Given this list of marker genes JCHAIN, ANAPC16, AP2A2, MTCH1, CEBPB, SMYD1, FAM3B (FAM3 metabolism regulating signaling molecule B), JPH3, ZC3HC1, CAPN5, CPT2, NDRG3, FGF8, SLC2A2, POLDIP3, SLC29A1, MAPK9, TIMELESS, CDC45, CTTN, CHIC1, UFD1, NPY1R, AXL (NCBI Gene Id 558), F5, RAB3D, AGTRAP, SLC22A9, TBC1D22A, FAM241A, DXO, ARF5, CHMP3, TUBB, RTL6, MYCBP, SYNGR2, SURF4, GTF2H4 (NCBI Gene Id 2968), CENPE, SUV39H2, PRLR, KRT18, S100A14, GNA12, NDC80, PSMD5, EXO1, HSF2, HPS1, SYNGR1, SAA4, PKN2, TNFRSF11A, MCM7, MTMR10, CANT1, NDE1, SDC4, BCL2L1, SMAD3, TRPC4, ARFGAP3, NUP85, PPP6R3, VPS72, OMD, EPB42, RENBP, CD47, NUP107, DNTT (NCBI Gene Id 1791), SEMA3E, IL12A, MEF2C, BRAP (NCBI Gene Id 8315), MYO1E, DOCK5, COL15A1, CXCL12, NRP1, HDAC7, FGF12, RPS6KA3, YY1, SYT6, RASGRP2, FHOD3, CTSD, DDR1, TNFRSF21, EDEM1, PKD2, MKLN1, OCA2, PDE1C, TMEM176B, SMOC1, H1-2, NEUROD4, FOXF2, PIAS1, ST8SIA1, ELOVL2, CLU, MC2R, LYVE1, FES, HOXA10, AFF1, NXN, CYP3A43, AP1M1, KLF3, NNAT, CRYGB, CIDEA, CDC42EP4, SUCLG2, ETS2, CFAP418, LTA4H, PARM1, PTPRK, SPDL1, CCND3, MTR, MKI67, SDC1, RPL35, ANXA2, CYP19A1, CTNNAL1, ACP2, TCHH, USP21, DHRS3, INMT, IL12RB2, SLC25A25, ANAPC5, HHEX, SRXN1, POPDC3, HAPSTR1, ANTXR2, UBAP1, PITPNB, PLEKHH1, PTMS (NCBI Gene Id 5763), ASNS, REPS1 (RALBP1 associated Eps domain containing 1), PPP2R1A, SRPK2, NAA40, CAVIN1, ATXN1, PTPRN2, SERPINB2, DMTN, SELL, CCNF, TNC (tenascin C), DENND5A, MYO10, TPMT, ST6GALNAC3, ADGRE1, SRPK1, RAD50, PPIF, XIAP, RNF26, PYCR2, PADI2, AOC1, KIF2C, DAGLB, E2F1, OSBPL1A, AURKA, TSPYL1, MCM5, RAMP2, ALG3, HAT1, HLA-DOB, GABRB3, SLA, IDH3A, NCAPH, TPBG, STAR, SPIB, DPAGT1, CDR2L, ELK3, RAB3IP, PAFAH2, RASAL3, here is a description of the gene set: Human Gene Set: GSE1925_CTRL_VS_IFNG_PRIMED_MACROPHAGE_UP species: Homo sapiens IFN-gamma transcriptional responses in control and IFN-gamma primed primary human macrophages Genes up-regulated in control macrophages: untreated versus primed by IFNG. from publication Hu X, Park-Min KH, Ho HH, Ivashkiv LB (PMID 16148108)